The following is a description of a gene set: studied in species Mus musculus The biological process whose specific outcome is the progression of a bronchus from an initial condition to its mature state. This process begins with the formation of the bronchus and ends with the mature structure. The bronchus is the portion of the airway that connects to the lungs. Mouse Gene Set: GOBP_BRONCHUS_DEVELOPMENT, and this is the list of marker genes: Spdef, Hoxa5, Agr2, Tulp3, Foxp1, Adamtsl2, Foxp4, Wnt7b, Sox9, Srf, Tgfbr2, Bmp4